Given this list of marker genes HLA-A, TAPBP, TAP1, PDIA3, B2M, TAP2, TAPBPL, CALR, here is a description of the gene set: A large, multisubunit complex which consists of the MHC class I-beta 2 microglobulin dimer, the transporter associated with antigen presentation (TAP), tapasin (an MHC-encoded membrane protein), the chaperone calreticulin and the thiol oxidoreductase ERp57. Functions in the assembly of peptides with newly synthesized MHC class I molecules. studied in species Homo sapiens Human Gene Set: GOCC_MHC_CLASS_I_PEPTIDE_LOADING_COMPLEX